The following is a description of a gene set: The initial formation of a blastocyst from a solid ball of cells known as a morula. Human Gene Set: GOBP_BLASTOCYST_FORMATION species: Homo sapiens, and this is the list of marker genes: TET1, RRP7A, HAND1, CCNB1IP1, NLE1, MFNG, EOMES, ZP3, SUPT6H, TEAD4, SOX17, YAP1, KDM4C, MATR3, NODAL, PTPN18, GABPA, SRF, MFN2, CNOT2, PNLDC1, SP3 (NCBI Gene Id 6670), MXI1, CNOT3, NR5A2, RTN4, RBM46, LATS1, HNF1B, TFAP2C, SKIL, WDR74, CTR9, CITED2, ADA, LATS2, RPL7L1, CNOT1, PRDM14, JUNB, BYSL, ACTL6A, FURIN, SF3B6, CDX2, HOPX, TM4SF1, CUL3